Given this list of marker genes Pax6, Nfix, Ascl1, Sox6, Olig2, Nkx2-2, Nfib, Nfia, Sox9, here is a description of the gene set: The process in which a cell becomes capable of differentiating autonomously into a glial cell in an environment that is neutral with respect to the developmental pathway. Upon specification, the cell fate can be reversed. species: Mus musculus Mouse Gene Set: GOBP_GLIAL_CELL_FATE_SPECIFICATION